The following is a description of a gene set: species: Homo sapiens part of: Kidney development A nephron of an amniote such as mouse or human comprises the glomerulus where small molecules are filtered out of the blood, the proximal tubule and the loop of Henle where small molecules are selectively reabsorbed, the thick ascending limb, the macula densa, the distal convoluted tubule, the connecting tubule, and the collecting duct which drains into the ureter.<br>Initiation of nephron development occurs at the termini of the branches of the ureteric bud where cells of the ureteric bud interact with cells of the metanephric mesenchyme. Rather than differentiating in place, analysis of cellular migration indicates that progenitors are recruited from the mesenchyme to the developing epithelial elements of the nephron. The transcriptional program that operates during human nephrogenesis has been mapped in extraordinary detail. WNT9B secreted by the ureteric bud induces a subset of renal progenitor cells to aggregate and express WNT4, which causes the pre-tubular aggregates to further undergo a mesenchymal to epithelial transition to form renal vesicles (inferred from mouse embryos in Park et al. 2007, reviewed in El-Dahr et al. 2008, Costantini and Kopan 2010, Desgrange and Cereghini 2015). A subset of renal progenitor cells express SIX2 and respond to WNT9B by proliferating to maintain a renewing population of renal progenitors. The reason for the difference in responses may be the local concentration of WNT9B (inferred from mouse embryos in Ramalingam et al. 2018) or the presence of the transcription factor SIX2 (inferred from mouse embryos in Karner et al. 2011).<br>The renal vesicle becomes polarized early. The distal region contains a gene regulatory network containing LHX1, POU3F3 (BRN1), DLL1, and JAG1. LHX1 is required for proximo-distal differentiation (inferred from mouse embryos in Kobayashi et al. 2005) and POU3F3 participates in elongation of the loop of Henle and formation of the distal convoluted tubule (inferred from mouse embryos in Nakai et al. 2003). The proximal region of the renal vesicle expresses WT1, which directly represses PAX2 to enable formation of podocytes (inferred from mouse homologs in Ryan et al. 1995). The renal vesicle develops into the comma-shaped body in which HNF1B in the distal region activates NOTCH pathway components DLL1, JAG1, and LFNG (inferred from mouse embryos in Heliot et al. 2013). The comma-shaped body in turn develops into the S-shaped body in which HNF1B activates IRX1 and IRX2 in the intermediate region (inferred from mouse embryos in Heliot et al. 2013). Podocytes, the proximal tubule, the intermediate tubule, and the distal tubule then differentiate. Reactome Pathway: Nephron development, and this is the list of marker genes: DLL1, LFNG (LFNG O-fucosylpeptide 3-beta-N-acetylglucosaminyltransferase), JAG1, IRX1, WNT9B, HNF1B, PAX2, LHX1, WT1, POU3F3, IRX2, HNF4A, WNT4